The following is a description of a gene set: from publication Gautier EL, Chow A, Spanbroek R, Marcelin G, Greter M, Jakubzick C, Bogunovic M, Leboeuf M, van Rooijen N, Habenicht AJ, Merad M, Randolph GJ (PMID 22855714) PPARγ is known for its anti-inflammatory actions in macrophages. However, which macrophage populations express PPARγ in vivo and how it regulates tissue homeostasis in the steady state and during inflammation is not completely understood. We show that lung and spleen macrophages constitutively expressed PPARγ, while other macrophage populations did not. Recruitment of monocytes to sites of inflammation was associated with induction of PPARγ as they differentiated to macrophages. Its absence in these macrophages led to failed resolution of inflammation, characterized by persistent, low-level recruitment of leukocytes. Conversely, PPARγ agonists supported an earlier cessation in leukocyte recruitment during resolution of acute inflammation and likewise suppressed monocyte recruitment to chronically inflamed atherosclerotic vessels. In the steady state, PPARγ deficiency in macrophages had no obvious impact in the spleen but profoundly altered cellular lipid homeostasis in lung macrophages. Reminiscent of pulmonary alveolar proteinosis, LysM-Cre x PPARγflox/flox mice displayed mild leukocytic inflammation in the steady-state lung and succumbed faster to mortality upon infection with S. pneumoniae. Surprisingly, this mortality was not due to overly exuberant inflammation, but instead to impaired bacterial clearance. Thus, in addition to its anti-inflammatory role in promoting resolution of inflammation, PPARγ sustains functionality in lung macrophages and thereby has a pivotal role in supporting pulmonary host defense. species: Homo sapiens Genes up-regulated in Ly6C high monocytes: untreated versus rosiglitazone. Human Gene Set: GSE32034_UNTREATED_VS_ROSIGLIZATONE_TREATED_LY6C_HIGH_MONOCYTE_UP, and this is the list of marker genes: RO60, NOP58, UBALD2, PDLIM7, STOM, AQP8, KCMF1, PFDN6, CDC37, TIA1, LAMC2, PRKACA, EN1, LAPTM4B, PCLO, ABCC1, ACY1, ACKR4, CINP, ATP7A, ADH7, NR2C1, AQP9, MAP2K3, GIPC2, ELK1 (NCBI Gene Id 2002), C12orf43, BMP2, EXT1, L1CAM, POLR1A, IGF2BP2, ENO1, MORC4, SLC2A1, ESD, IL2RG, FABP4, GUCA1A, FARSA, MYO10, ANK3, NOLC1, ST3GAL5, CCR1, ABCB10, TM4SF1, RLN1, KCNU1, ABR, ANGPTL2, SMAD6, RAB4B, CENPB, DNASE1L2, FNDC1, MSR1, NINJ1, HAL, PTH (parathyroid hormone), VIM, INPP1, ZFP28, COL5A1, RAD23A, UCK1, ENTPD1, GSX1, OCEL1, NAV2, PTGDS, KDR, CCL13, SLC11A1, CHADL, ELL2, NCF1, EMD, IKBIP, DNAH8, HOXA5, FLNB, RPL15, MERTK, SH2B3, MRPS18B, CAPN3 (calpain 3), PLK3, TIMP2, TYK2, USP22, CLCN7, URM1, ARHGEF1, CSNK1D, CXCL3, CCNE1, AARS1 (NCBI Gene Id 16), FBXW7, HSD11B2, VAX1, HBE1, SLC6A8 (NCBI Gene Id 6535), UBQLN1, SPDL1, ARF3, FXN, TFF3, LAMC1, PTPN22, CX3CR1, PHTF2, PLXNA2, GCSAM, COX18, ITGA5, INTS14, RAB8B, MINDY1, GSR, ESRP2, HOPX, PDK4, MTM1, INMT, SCAMP3, ATP5MC1, POLG, KCNN4, CADM1, SEMA4A, CASP4, SLC19A1, F7, NPC1, VCAN, RGCC, VPS37B, FAM3A, IKBKE, GEMIN5, SLC35E4, PDK1, NFIC, SEPTIN9, HMGA2, PIGU, IL7R, MMP12, PROCR, STRBP, ZBTB2, CASQ1, TXNRD1, KCNAB1, CFAP418, SLC44A2, NFE2L1 (NFE2 like bZIP transcription factor 1), AQP7, NKX1-2, RRS1, TUSC2, DNAAF10, MRPL15, TNFAIP2, GCLM, C5AR1, ZNF239, ABCF2, SDC1, TIMM17B, MRPL17, MEMO1, CYP8B1, ERCC1, FGR, SIT1, GTF2E2, TIMELESS, CA8, WWC2, GPX4, LRRC23, HMOX1, PHC2, GPR137B, PMF1 (NCBI Gene Id 94958), TANC1, H1-2, PEF1, CTSE, ADPRS (NCBI Gene Id 54936), DIAPH1, NES, GJB2, S100A11, NSF, GTF2B (NCBI Gene Id 2959), PPP3CC, PVALB (parvalbumin)